The following is a description of a gene set: studied in species Homo sapiens Human Gene Set: GOCC_PROTEASOME_CORE_COMPLEX A multisubunit barrel shaped endoprotease complex, which is the core of the proteasome complex., and this is the list of marker genes: PSMF1, PSMB5, PSMA6, PSMB2, PSMB7, PSMB1, PSMB3, PSMA5, PSMA1, PSMB8, PSMA7, PSMB10, PSMA8, PSMA2, PSMA4, PSMB9, PSMB6 (proteasome 20S subunit beta 6), PSMB4, PSMA3, PSMB11